The following is a description of a gene set: from publication Chen Y, Wang X (PMID 31504780) Human Gene Set: MIR3180_MIR3180_3P Genes predicted to be targets of miRBase v22 microRNA hsa-miR-3180, hsa-miR-3180-3p in miRDB v6.0 with MirTarget v4 prediction scores > 80 (high confidence targets). species: Homo sapiens, and this is the list of marker genes: DLGAP3, KLK9, PPFIA3, PAX2, GRB10, PRR36, DPF1, ANKS1B, SLC29A3 (NCBI Gene Id 8072), FGD5, GRIN1, TRIM48, ATP1A3, SPATA33, VSTM2L, ZNF385A, NFIX, AAK1 (AP2 associated kinase 1), SCRT1, SOBP